Given this list of marker genes HOXA1, SPARC, FGF10, NR4A3 (nuclear receptor subfamily 4 group A member 3), TBX3, EYA1, ZEB1, TBX1, CHD7, here is a description of the gene set: species: Homo sapiens Human Gene Set: GOBP_SEMICIRCULAR_CANAL_MORPHOGENESIS The process in which the anatomical structures of the semicircular canals are generated and organized.